The following is a description of a gene set: Mismatch repair Mouse Gene Set: WP_MISMATCH_REPAIR studied in species Mus musculus, and this is the list of marker genes: Exo1, Pold1, Pcna, Rpa1 (replication protein A1), Mlh1, Msh6, Lig1 (NCBI Gene Id 16881), Msh2, Rfc1